Given this list of marker genes RGS1 (NCBI Gene Id 5996), H3-3B (H3.3 histone B), HLA-DMB, GOLM2, ATP2C1, ENSG00000221638, MRPL22, DAD1, EPCIP-AS1, CCR9, ATP6V1G1, PER1, H2AC13, TAT-AS1, GRAMD1B, BIRC3, LINC03034, POLR3A, TBC1D1, STIP1 (NCBI Gene Id 10963), TRMT1, FAM230G, LINC02909 (long intergenic non-protein coding RNA 2909), H2BC13, H2BC5, MTCO3P12, MCM3, TLL2, KLHDC9, H2BC7, H4C3, IL21R, CPAMD8, ENSG00000255476 (NCBI Gene Id 101928008), HAGH, UBALD2, CEP128, STAP2, FAHD1, GNAS, WDCP, ARID4A, DNAJB4, HYLS1, H2AC5P, LYSMD1, FNDC3A, LINC02977, NLRP4, MPND, H2BC15, SNORD59A (small nucleolar RNA, C/D box 59A), RAB4B-EGLN2, TMEM277P, TRAFD1, BTRC, ARMC1, PAXIP1-AS2, RHEX, ARMH4, H2BC14, SCNM1, RAB4B, ZNF19, DUSP19, FCRL4, KATNB1, ATP5F1B, CDK1, SYTL3, PSMA3-AS1, BABAM1, H2BC16P, H2AC14, ILF2, CYTIP, H2AC7, PAXBP1, H2BC3, CD209, H2AC15, LCP1, VXN, H2AC16, here is a description of the gene set: Genes containing one or more binding sites for (CENPT) in their promoter regions (TSS -1000,+100 bp) as identified by GTRD version 20.06 ChIP-seq harmonization. from publication Yevshin I, Sharipov R, Kolmykov S, Kondrakhin Y, Kolpakov F (PMID 30445619) Human Gene Set: CENPT_TARGET_GENES studied in species Homo sapiens